Given this list of marker genes Cnga4, Tppp, Fbxw2, Ttll7, Hsd11b2, Hira, Rasl11a, Pikfyve, Acad11, Gria4, Ccdc85a, Csnk1a1, D16Ertd472e, Celf1, Relch, Ccdc88a, Ecscr, Zfp74, Or7d10, Plekhf1, Wnk1, Rock1, here is a description of the gene set: studied in species Mus musculus from publication Chen Y, Wang X (PMID 31504780) Mouse Gene Set: MIR_325_5P Genes predicted to be targets of miRBase v22 microRNA mmu_miR_325_5p in miRDB v6.0 with MirTarget v4 prediction scores > 80 (high confidence targets).